The following is a description of a gene set: Human Gene Set: ARNT_02 species: Homo sapiens Genes having at least one occurrence of the motif NNNNNRTCACGTGAYNNNNN in the regions spanning 4 kb centered on their transcription starting sites. This matches the ARNT transcription factor binding site V$ARNT_02 (v7.4 TRANSFAC)., and this is the list of marker genes: BRD2, GET4, NFATC3, ADAMTS3, ACAP3, TUBA4B, TIMM8A, TSSK3, RALYL, RBBP4, MICU1, GGN, TRAPPC8, HRH3, ZMYND12 (NCBI Gene Id 84217), LZTS2, EGLN2, ARMCX6, ATF7IP, SLC26A10P, PURA, SLCO5A1, SPG21, THUMPD2, GIGYF2, GAPDH, RNF146 (NCBI Gene Id 81847), HOXD10, RRAGC, CREBRF, OGDHL, PA2G4, GPM6B, GLYR1, SGK1, PRKCE, CUL5, PRKCG, HNRNPH2, SNN, C1orf43, ELAVL3, HOXA7, SNTB2 (syntrophin beta 2), ZIC1, EPB41L4B (erythrocyte membrane protein band 4.1 like 4B), PKN1, CPEB4, RAB24, CBX5, NFX1, BDNF, PSME3, USP31, SLC43A1, TRIM55, PRDM4, CSK, EIF4G1, ATP6V1A, HPS5, ATP6V1H, DIP2B, SNX2, TCEAL3, SLC49A4, PRELID1 (PRELI domain containing 1), CHRM1, NCL, MRPL27, DLX2, RRP15, TRPM7, KBTBD2, U2AF2, SLC38A7, SAE1, VPS37B, SLCO1C1, HOXB5 (NCBI Gene Id 3215), YEATS2, HIF1A, FABP3, LONP1, ANAPC13, EME1, NAA50, UBE2B, HNRNPA1, GYG1, MANF, VPS26A, RAB31, SPNS1, ZFYVE26, HEXA, KLF11, RAD9A, CPT1A, CCNYL1, CD164, CIART, SLC38A5, TGIF2, RPS2, BAX, STX6, KAT5, SNX16, DSCAM, FOXRED2, MAFF, OBI1, ADISSP, APEX1, AFF4, RGL1, HPS3, FBXL19-AS1, MARCHF8, FLVCR2, SPPL3, GMFB, ALDH6A1, FOXD3, PES1, SOCS2, NEUROD2, IFRD2, TMEM258, HOXA1, RAP1GAP, CLN3, BEX1, AGRP, NPTN, IGF2BP3 (NCBI Gene Id 10643), GTF2H1, CDK5R1, HOXA9, PTPRF, SIRT1, POLR3C, TRIM3, CBX6, CANX, ANKRD17, HAPSTR1, NOTCH1, MFSD5, NDUFA7, ZBTB8OS, ZBTB10, DCTN4, UBR5, CDKN2C, ARPC5, EN1, VLDLR, DEPDC7, PIAS4, CBARP, RFX4, RETREG2, PRRC2C, LTBR, BEX3, LRRC59, RNF115, UBE4B, AVPI1, PDCD6IP, HOXC5, ALG1, ATP6V1C1, EIF4B, CNNM1, OSGEP, RAB30, REEP3, ARMCX3, LAMP1, RRAGB, PPCS, NSD3, SLC35A5 (solute carrier family 35 member A5), ICAM5, ATP7A, AMER1, FAM13B, PICALM, STMN1, CUTA, NUP62CL, URI1, SEC23IP, KAT14, ANKHD1, VGF, COMMD8, FBXL19, IRS4, RPS28, RNF44, GATA4, INSM1, AATF, CEP63, TCEAL1, PRPS2 (phosphoribosyl pyrophosphate synthetase 2), MRPL40, CAMK2D, GNB2, GET3, BHLHE41, NR1D1, TUG1, UBR4, FEN1, IGF2R, SYNCRIP, HIRA, DNAAF6, RCOR2, EPC1, ZBTB40, LNPK, REV1, JOSD1, SHOC1, MTCH2, BLOC1S1, FXYD6, ANKHD1-EIF4EBP3, CNPPD1, KCNE4 (NCBI Gene Id 23704), WASHC4, SMNDC1, TUBA4A, GLA, AKAP1, CATSPERD, NPTX1 (NCBI Gene Id 4884), RABGAP1, CLTC, TADA1, OLFM2, FAM117A, HMGA1, TOPORS, UTP18, SLC36A1, ATF4, HSPBAP1, H2AZ1, GNAS